The following is a description of a gene set: Mouse Gene Set: GOBP_DIBENZO_P_DIOXIN_METABOLIC_PROCESS The chemical reactions and pathways involving dibenzo-p-dioxin, a substance composed of two benzene rings linked by two ether bonds. Dibenzo-p-dioxins are generated as by-products in the manufacturing of herbicides, insecticides, fungicides, paper pulp bleaching, and in incineration, and can accumulate in milk and throughout the food chain, creating significant health concern. studied in species Mus musculus, and this is the list of marker genes: Cyp1b1, Star, Prkcb, Cyp1a1, Srd5a2, Cyp1a2